Given this list of marker genes NSMCE4A, NSMCE3, RAD21, PCBP2, BRD2, NSMCE1, CASC11, JPX, NIPBL, NSMCE2, EID3 (NCBI Gene Id 493861), SMC6, SLF2, SLF1, SMC5, CTCF, here is a description of the gene set: studied in species Homo sapiens Human Gene Set: GOBP_CHROMATIN_LOOPING A chromatin organization process that starts with the loading of an extrusion motor (by an SMC family complex) onto the chromatin, followed by chromatin extrusion that stops at loop anchoring sites on the chromosome.